Given this list of marker genes Cdk4, Ccnd1 (NCBI Gene Id 12443), here is a description of the gene set: This event has been computationally inferred from an event that has been demonstrated in another species.<p>The inference is based on the homology mapping from PANTHER. Briefly, reactions for which all involved PhysicalEntities (in input, output and catalyst) have a mapped orthologue/paralogue (for complexes at least 75% of components must have a mapping) are inferred to the other species. part of: Cyclin D associated events in G1 electronically inferred by orthology from the curated human pathway Reactome Pathway: Drug-mediated inhibition of CDK4/CDK6 activity studied in species Mus musculus